The following is a description of a gene set: Any process that modulates the frequency, rate or extent of a dopamine receptor signaling pathway activity. A dopamine receptor signaling pathway is the series of molecular signals generated as a consequence of a dopamine receptor binding to one of its physiological ligands. Human Gene Set: GOBP_REGULATION_OF_DOPAMINE_RECEPTOR_SIGNALING_PATHWAY studied in species Homo sapiens, and this is the list of marker genes: PALM, PRMT5, VPS35, RGS4, RGS8, DTNBP1, LRRK2 (NCBI Gene Id 399472), DRD3, DRD2, CAV2, ALK